The following is a description of a gene set: Human Gene Set: GOBP_REGULATION_OF_NUCLEAR_CELL_CYCLE_DNA_REPLICATION Any process that modulates the frequency, rate or extent of The DNA-dependent DNA replication that occurs in the nucleus of eukaryotic organisms as part of the cell cycle. studied in species Homo sapiens, and this is the list of marker genes: AICDA, FGFR1, DACH1, INO80, TIPIN, WIZ, DBF4B, CDT1, ATRX, NUGGC, BCL6, ZMPSTE24, DBF4, CDC7